The following is a description of a gene set: species: Homo sapiens A P granule that contains the PIWIL2-TDRD1 module, a set of proteins that act in the primary piRNA pathway. The pi-body corresponds to the cementing material between mitochondria found in gonocytes. Human Gene Set: GOCC_PI_BODY, and this is the list of marker genes: TDRD5, ASZ1, PIWIL2, MOV10L1, DDX4, ANKRD34C, ANKRD34B, TDRKH, ANKRD34A, TDRD1